Given this list of marker genes MT2A, DAXX, AQP1, MT1M, MT4, CYP1A1, MT3, MAP1LC3A, NFE2L2, NFE2L1, APP, HSF1, SNCA, MT1A, MT1B, BECN1, PRNP, AQP2, MT1F, MT1H, MT1G, MT1HL1, MT1DP, BACE1, MT1X, MT1E, here is a description of the gene set: studied in species Homo sapiens Human Gene Set: GOBP_CELLULAR_RESPONSE_TO_COPPER_ION Any process that results in a change in state or activity of a cell (in terms of movement, secretion, enzyme production, gene expression, etc.) as a result of a copper ion stimulus.